The following is a description of a gene set: Human Gene Set: HESS_TARGETS_OF_HOXA9_AND_MEIS1_DN from publication Hess JL, Bittner CB, Zeisig DT, Bach C, Fuchs U, Borkhardt A, Frampton J, Slany RK (PMID 16507773) studied in species Mus musculus Abdominal-type HoxA genes in combination with Meis1 are well-documented on-cogenes in various leukemias but it is unclear how they exert their transforming function. Here we used a system of conditional transformation by an inducible mixed lineage leukemia-eleven-nineteen leukemia (MLL-ENL) oncoprotein to overexpress Hoxa9 and Meis1 in primary hematopoietic cells. Arrays identified c-Myb and a c-Myb target (Gstm1) among the genes with the strongest response to Hoxa9/Meis1. c-Myb overexpression was verified by Northern blot and quantitative reverse transcription-polymerase chain reaction (RT-PCR). Also MLL-ENL activated c-Myb through up-regulation of Hoxa9 and Meis1. Consequently, short-term suppression of c-Myb by small inhibitory RNA (siRNA) efficiently inhibited transformation by MLL-ENL but did not impair transformation by transcription factor E2A-hepatic leukemia factor (E2A-HLF). The anti c-Myb siRNA effect was abrogated by coexpression of a c-Myb derivative with a mutated siRNA target site. The introduction of a dominant-negative c-Myb mutant had a similar but weaker effect on MLL-ENL-mediated transformation. Hematopoietic precursors from mice homozygous for a hypo-morphic c-Myb allele were more severely affected and could be transformed neither by MLL-ENL nor by E2A-HLF. Ectopic expression of c-Myb induced a differentiation block but c-Myb alone was not transforming in a replating assay similar to Hoxa9/Meis1. These results suggest that c-Myb is essential but not sufficient for Hoxa9/Meis1 mediated transformation. Genes down-regulated in hematopoietic precursor cells conditionally expressing HOXA9 and MEIS1., and this is the list of marker genes: C5AR1, ANXA4, SLC11A1, CDH1, P2RY14, S100A4, ZFP36 (ZFP36 ring finger protein), ANXA1, TGFBI, SLFN12, CD300LF, ARG2, TRPV2, IL1R2, MSR1, MMP9, LIPA, IL1B, DUSP1, LPL, MS4A6A, CXCL2, LYZ, TLR2, BTG2, STX3, FOS, SIRPA, FFAR2, CA4, PSAP, EGR2, CCL23, FCGR1A, CPT1A, CAMK2D, EHD1, MYADM, CSF1R, CTSS, FPR2, GCNT2, MITF (melanocyte inducing transcription factor), KLF4, UPP1, DAB2, CTSV, C3AR1 (NCBI Gene Id 719), EGR1, CCN3, TF, CLEC7A, MMP8, CCR5, RNASE3, PLEK, PLSCR1, FGR, CSF2RB, PHLDA1, VCAN, MCL1, MRC1, MPEG1, GRK5, LCN2, H1-2, NDRG1, CYBB, SAMHD1, CHIA, LITAF, ZFP36L1, FPR1, GPR137B, MERTK, PILRB, CLEC4A, TPD52, LSP1, ID2 (NCBI Gene Id 3398), IL18 (interleukin 18), HCK, AQP9